The following is a description of a gene set: species: Homo sapiens Human cytomegalovirus (HCMV) induces pro-inflammatory monocytes following infection and we have evidence that phosphatidylinositol 3-kinase is a key mediator in this activation. To begin to address how this signalling pathway is responsible for the functional changes in infected monocytes, we examined the role this pathway played in the transcriptome of infected monocytes. Global transcriptional profiling using cDNA microarrays revealed a significant number of genes were regulated in a PI(3)K-dependent manner, identifying this pathway as a key cellular control point in the conversion of monocytes to an activated pro-inflammatory state following HCMV infection. Genes up-regulated in monocytes pre-treated with Ly294002: control versus HCMV infection. Human Gene Set: GSE19772_CTRL_VS_HCMV_INF_MONOCYTES_AND_PI3K_INHIBITION_UP from publication Chan G, Nogalski MT, Bentz GL, Smith MS, Parmater A, Yurochko AD (PMID 20173022), and this is the list of marker genes: RTKN, UPB1, ATP1A2, CLIP2, TPCN2, SPZ1, MAGEB6, H4C9, ABL2, LINC01711, RRN3P3, PREB (prolactin regulatory element binding), ST20, PIGA, CREB5, TMEM41B, MLF2, NUP54, EMC8, SELENOI, SSTR4, GOLPH3, SEC23IP, MRPS18C, H2AC14, ZNF417, TRIM51, DBNL, OPA3, CLSTN2, ZNF398, CHRNA1, S1PR5, OR3A3, TRIM61, LIN37, VENTX, SDHC, ELOA, PNPLA1, TRIB1, SCN3B, TUBA1B, SRM, CBR1, MRPS22, GLRX2, C9orf152, PUDP, PATE2, MIEF1, POU4F2, GLYATL1, DAZAP1, BIRC2, AKAP8, CACNA1G-AS1, SLC35A2, LRRC2, NOL6, CIMAP1C, POLR3A, POLE3, SGSM3, STAR, FBXO28, PLPPR2, CCNJ (cyclin J), PDE4B, CDH12, GPR50, LINC02297 (NCBI Gene Id 652850), BTLA, SH3RF3, SSMEM1, PIK3CD, STARD13 (StAR related lipid transfer domain containing 13), BIRC3, ZNF322, H2AX, ZNF407, FASN (NCBI Gene Id 2194), TUBA1C, RLIG1, MICALL1, ZZEF1, SAMD4B, IPPK, INSC, HGH1, DCUN1D5, CNEP1R1, USP7, DDI2, GOPC, LEMD3, DCP1A, DDX27, EBNA1BP2, SRP68, TP53INP2, TCF24, CTCF, DHRS2, ASIC1, PRF1, SLC52A2, ALG13, GAN (NCBI Gene Id 8139), SRP54, NABP1, GOLGA2, SLC25A44, TSR3, PPP2R2D, SYNCRIP, LRRC8E, RIC8A, UBE2S, BET1L (NCBI Gene Id 93155), IL17RA, MTMR9, SOCS4, OTULIN, COQ10B, TEX30, CCDC12, ZNF791, ACSM2A, C2CD2L, KLHL42, PPP2CA, LINC01226, RPP40, MYO9B, GSK3A, LSG1, MPHOSPH6, WDR26, USP36, ZNF777, SLC2A6, CHPF2 (chondroitin polymerizing factor 2), PRRC1, C1orf162, PRPF40A, CBFB, SHROOM1, NKX3-1, SMTN, TMEM33, LANCL2, LPP, LMO1, REEP2, LMNB2, NUDC (nuclear distribution C, dynein complex regulator), HES6, LINC01096, DTHD1, PRPF3, APOA5, RPH3AL-AS1, STARD8, KCNJ16, ATG4D, NFKBIZ (NCBI Gene Id 64332), POLR3G, TSTD2, RCSD1, KIAA0319, MYBBP1A, PPP1R8, TRIM62, CFAP95-DT, MYO10, SPMIP3, MIER2, SGPL1, TOE1, CCIN, CHRND, PRPF6, LAMC2, ATP2A2 (NCBI Gene Id 488), ENTPD7, BMS1, CTTNBP2NL, RAB5IF, ZBTB11, CYCS, JAGN1 (NCBI Gene Id 84522), ARL2BP, DEXI